The following is a description of a gene set: Mouse Gene Set: GOBP_REGULATION_OF_CELLULAR_COMPONENT_BIOGENESIS species: Mus musculus Any process that modulates the frequency, rate or extent of cellular component biogenesis, a process that results in the biosynthesis of constituent macromolecules, assembly, and arrangement of constituent parts of a cellular component., and this is the list of marker genes: Mtm1, Fhod1, Rpl13a, Enpp7, Pdlim4, Cln3 (NCBI Gene Id 12752), Tenm1, Map2, Spice1, Prkcq, Nrg2, Plcg2, Neurl1a, Cdc42ep1, Nol3, Wrap73, Cdh5, Akirin1, Kirrel1, Piezo1, Dync2li1, Ajuba, Gsn, Coro1c, Ptpn1, Mavs, Dlc1, Ubap2l (ubiquitin-associated protein 2-like), Arhgap6, Flna, Psd, Wnt10b, Nrxn1, Asic1, Nphp1, Arhgap33, Epha2, Rock2 (NCBI Gene Id 77848), Poc1b (POC1 centriolar protein B), Nek7, Sar1b, Dhx33, Vps35, Clec2i, Abcb7, Arpc5l, Vldlr, Becn1, Ect2, Tbc1d14, Rnf5, Mapk9, Apoa1, Cdc34b, Met, Camsap3, Hgs, Sacs, Chek2, Igsf11, Lcat, Abca1, Nr1h2, Ssh2, Atg5, Cd24a, Npm1, Trabd2b, Cldn3, Lamp2, Prkn, Dynll1, Eef2k, Hspa2, Capg, Lpar1, Gba1, Ccl26, Rap1b, Clip1, Arhgap44, Ulk1, Kank2, Plekhg2, Abi3bp, Chmp7, Brcc3, Vps4a, Nup62, Hcfc1, Grid2, Ckap5, Chd4, Rhoc, Stxbp6, Stmn1, Gpm6a, Usp17le, Cep295, Nectin1, Cdk2, Frmd7, Hsp90aa1, Srcin1 (NCBI Gene Id 56013), Ica1, Wipi1, Rims1, Slf2, Arpc3, Trim32, Vasp, Plce1, Hdac6, Rgcc, Palm, Ublcp1, Map4k4, Negr1, Ptger4, Tie1, Ptk2b, Espn (NCBI Gene Id 56226), Clstn1, Was, Smad4, Sorbs3, Tesk1, Nckap1l, Apod, Ulk4, Patl2, Ube3b, Trhr, Hrk, Mtpn, Tlr4, Pfn5, Ccn1, Osbpl2, Vil1, Dock1, Sec22b, Il1rapl1, Mapre3, Slain2, Stmp1, Ptpn22, Tfip11, Slit1, Lrrc24 (NCBI Gene Id 378937), Tbc1d30, Mmp14, Stmn2, Sipa1l1, Peak1, Plk2, Wnt4, Rnf186, Actr2 (actin related protein 2), Gpr65, Map1b, Dynlt2b, Cep97, Crb3, Prkaca, Scin, Bcl2l11, G3bp2, Cep135, Tgfbr1, Cyfip2, Sptbn1, Adgrl4, Arf4, Arhgef15, Iqsec1, Oprd1 (opioid receptor, delta 1), Ehmt2 (NCBI Gene Id 52041), Zdhhc8, Ikbke, Usp9x, Tchp, Vcp, Adgrb1, Chmp4c, Intu, Dnm2, Pdzd11, Fuz, Fas, Pecam1, Dnajc6, Abitram, Rps3, Sh3glb1, Mecp2, Hnf4a (NCBI Gene Id 15378), Lcmt1, Bag5 (NCBI Gene Id 74791), Usp10, Rac1, Carmil3, Prkch, Slit2 (NCBI Gene Id 338531), Mlst8, Mndal, Pan3, Gpsm2, Efnb3, Tbx5, F2rl1, Ep300, Slitrk3, Tmsb15l, Rhoa, Syngr3, Prkce, Dock4, Pum2, Eps8l3, Clstn2, Wnt7a, Il1rapl2, Sh3pxd2b, Marchf7, Kif14, Stxbp5, Fchsd1, Cobl, Rhpn1, Ticam1 (NCBI Gene Id 224899), Btk, Lmod3, Grin1, Arhgap40, Tubb4a, Unc13b, Ccsap, Zdhhc12, Trpm2, Dync1h1, Serpinf2, Icam1, Cdc42, Crocc (NCBI Gene Id 230872), Lefty1, Lrfn5, Rasip1, Cep76, Fer, Rab5a, Rack1, Hsf1, Capza3, Prrt2, Ntrk2, Sdccag8 (serologically defined colon cancer antigen 8), Nedd4l, Ifi213, Trim11 (tripartite motif-containing 11), Fam98a, Hmgb1 (NCBI Gene Id 15289), Lzts3, Podxl, Prkaa2, Lats2 (large tumor suppressor 2), Cux2, Shank3, Bax, Slx4, Snap25, Rab3gap1, Mark1, Snai2 (snail family zinc finger 2), L1cam, Selp, Isg15, Aida, Pip4k2b, Rhpn2, Birc2, Igtp, Ifi209 (NCBI Gene Id 98348), Fnip1, Rock1 (NCBI Gene Id 68785), Rab3a, Mdga2, Nf2, Sdcbp, Riok3 (RIO kinase 3), Isl1, Flii, Adgrl1, Arpc5, Ppp1r9b, Notch1, Adamts16, Mdm1, Bik, Amigo3, Esam, Napb, Lats1, Ripor2, Ormdl3 (NCBI Gene Id 66612), Ppfia1, Rbm10, Capn1, Vps4b, Svil, Twf1, Kank1, Snap91, Ppp1r35, Cldn1, Lrp4, Prkaa1, Ifi214, Arhgef5, Yap1, Htr4, Snx9, Slitrk5, Capza2, Epb41l5, Sema4a, Sema4c, Eln, Tac1, Ppm1f, Tnf, Trim47, Ormdl2 (NCBI Gene Id 66844), Def8, Tpm1, Tapt1, Mkks, Hspa1b, Sass6, Ddx3x, Hopx, Cript, Pex5, Prkcz, Terf1, Rbm14, Nrp1, Gda, Aqp1, Phldb1, Ephb2, Cgnl1, Lrrtm2, Arhgap28, D1Pas1 (NCBI Gene Id 98517), Creb1, Pfn3, Wars1 (NCBI Gene Id 640248), Akain1, Fbxl2, Cav3, Wdpcp (NCBI Gene Id 216560), Agrn, Slc12a5, Cbln2, Prune1, Evl, Tfrc, Ifi206, Crmp1, Sar1a, Cyria, Srgap3, Nlgn1, Snai1, Kat2b, Plek, Mtss1, Add1, Pikfyve, Nphs1, Clec7a, Abl1, Nck1 (non-catalytic region of tyrosine kinase adaptor protein 1), Chmp2b, Trappc12, Farp1, Srgap2, Stub1, Tppp3, Syk, Eif4g1, Noto, Baiap2l1 (NCBI Gene Id 66898), Oxt, Lima1, Ifnb1, St8sia2, Atg3, Pycard, Ncam1, Synpo, Chga, Sorl1, Fez1, Clu, Ttbk1, Rap2a, Ift140, Lingo4, Dbn1, Rab17, Dkk1 (NCBI Gene Id 13380), Ghrl, Fkbp4, Cck, Lrfn3, Ccl21d, Lzts1, Bid, Bdnf, Ccl11, Lmo4, Limk2, Cdc34, Ubqln2, Rac2 (NCBI Gene Id 19354), Adgrb3, Syndig1, Smad3, Dusp22, Slitrk6, Rac3, Dnajb1, Dlg1, Casp4, Lcp1, Mapk15, Srf, Col16a1, Trim31, Mdga1, Dapk3, Robo1, Msn (NCBI Gene Id 97596), Lrfn4, Rap1a, Ntng2, Cryab, Htt, Dact1, Mad2l2 (NCBI Gene Id 71890), Csf3, Tmem67, Vcl, Cep295nl, Hrg, Ptpn13, Clasp2, Cnot6, Plxnb3, Hck (hemopoietic cell kinase), Tal1, Eif4ebp1, Ptprj, Cdkl5, Mpp7, Sncaip, Inpp5j, Nlgn3, Arpc2, Lrrtm3, Myo3a, Jmjd6, Cttn, Arhgef10, Atat1 (alpha tubulin acetyltransferase 1), Pxn, Thy1, Mapt, Wnt11, Ifi207, Ttc8, Ikbkb, Ldb2, Ldb1, Rnf4, Gpbar1, Mstn, Wnt3a, Styxl1, Numbl, Prkca, Chmp2a, Sigmar1, Preb, Ndel1, Cdc42ep5, Ccl21b, Sirt3, Hspa8, Pak1, Nbdy, Csnk1a1, Ntn1, Atr, Tbc1d12, Plekhm1, Bin3, Nop53, Sh3yl1, Caskin1, Stam, Myo10, Arl2, Nme7, Tmod2, Daam2, Lhfpl4, Myadm, Skap1, Fmr1, Cx3cl1, Lrrc4b, Lrrn1, Fam107a, Dusp3, Cxcl13, Iqsec2, Rab11a, Wasl, Mtor, Plk1, Lrsam1, Nlgn2, Gak, Ahr, D7Ertd443e, Kcnk13, Adgrl2, Chmp1b2, Arhgef18, Stx18, Swap70, Dnaja4, Bbs10, Clrn1, Coro1a, Mettl18, Tgfb1, Ankra2, Adgrb2, Ube2m, Pde4dip, Slitrk1, Abhd17a, Hdac4, Chrnb2, Stx1a, Drg1, Zfp827, Xrcc5, Trp53, Abi3, Mefv, Ppp2r5b, Pfn2, Fermt1, Gja1, Pcsk5, Cldn19, Cdc42ep2, Irgm2, Map3k1 (NCBI Gene Id 26401), Gna13, Icam5, Cfl1, Flrt3, Senp6, Wnt1, Nckap1, Caprin1, Fermt2 (fermitin family member 2), Efnb1, Trem2, Dlg4, Gap43, Cdkn2a, Pqbp1, Klf5, Rtn4, Arhgef2, Hcls1, Cep192, Irx3, Zmynd10, Saxo1, Fhod3, Slx1b, S1pr2, Lmod1, Rab3gap2, Zmynd8, Nox1, Dnajb2, Pip4k2c, Rcc2, Cbln1, Cdh17, Lrrk2, Myo3b, Sphk1, Gdi2, Dut, Efna5, Cyfip1, Foxc2, Pik3r2, Lrrn3, Odad3, Abca2, Syne2 (NCBI Gene Id 630548), Stil, Wdr45, Nlrc3, Sirt2, Nae1, Napa, Ormdl1, Samd8, Rab11fip3, Wasf2, Slc39a12 (solute carrier family 39 (zinc transporter), member 12), Afdn, Cnot2, G3bp1, Sptan1, Mmp3, Mmp1b, Lgals3, Auts2, Rhod, Eps8, Id1, Ppm1e, Carmil2, Cdk5rap2 (CDK5 regulatory subunit associated protein 2), Csf2, Psrc1, Pdcd6ip, Rcc1, Pkp2 (NCBI Gene Id 71741), Carmil1, Traf2, Rictor, Cldn5, Vill, Ptpra, Sec16a, Tnfsf18, Tpr, Slk, Fez2, Rab7, Kdr, Fscn1, Chmp1a, Fgfr1, Pan2, Tppp, Pten, Cyld, Ambra1, Ift20, Fes, Ntrk1, Ercc1, Prickle1, Mien1, Kctd17, Sost, Capza1, Six4, Add2, Ankrd27, Bbs4, Ghsr, Ccdc15, Cdc42ep3, Gnl3l, Ntrk3, Usp16, Lrtm1, Nptxr, Baiap2, Ccl21a, Mapre1, Tjp1, Ikzf1, Ppp1r9a, Washc1, App, Chmp3, Wnt5a, Spta1, Ptpn11, Pak3, F11r, Ube2v2, Mcidas, Dbnl, Ccn2, Hap1, Snca, Lrtm2, Elavl2, Eps8l2, Lrrtm1, Epn1, Dag1, Sox9, Bbc3, Atp8b1, Epha7, Sema4d, Tenm2, Atmin, Prex1, Baiap2l2, Ifi208, Mapk8, Nck2 (non-catalytic region of tyrosine kinase adaptor protein 2), Flrt1, Tpbg, Dcdc2a, Evi5l, Prkd1, Src, Gpc4, Ctnnbip1, Tirap, Ralb, Slitrk2, Kiss1r, Sumo1, Myd88, Snx30, Rhoq, Akt1, Cep120, Pparg, Rab1b, Atp13a2, Has3, Terf2, Park7, Hspa1a, Dsg3, Ptk2, Dnajb6, Brk1, Apc, Eml3 (echinoderm microtubule associated protein like 3), Cntrob, Usp50, Cnot1, Ctnnb1, Ptprd, Atp7a, Numa1, Sdc1, Crtac1, Tbc1d7, Ephb3, Epha1, Shank1, Rala, Snf8, Cdk10, Rp1 (retinitis pigmentosa 1 (human)), Fam110c, Bag4, Lin7a (lin-7 homolog A, crumbs cell polarity complex component), Dock10, Hras, Alox15, Adgre5, Cc2d1a, Cldn7 (NCBI Gene Id 53624), Lin7b, Insm1, Ccl21e, Psmc6, Dab2ip, Gm14137, Fzd1, Nphp4, Hnrnpu, Bin1, Lims1, Crbn, Kif24, Rps6, Cand1, Entr1, Stxbp1, Srpx2, Mtmr3, Xaf1 (XIAP associated factor 1), Dpysl3, Stau2, Arhgef10l (Rho guanine nucleotide exchange factor 10-like), Colq (collagen like tail subunit of asymmetric acetylcholinesterase), Hes1, Tsc1, Plk4, Ace2, Git1, Mak, Dmtn, Thbs2, C9orf72, Moap1, Pak2, Dnajb8, Akap9, Rest, Dnm3 (NCBI Gene Id 98663), Cntnap2, Xlr3b, Chmp5, Camsap2, Arfgef1, Trim9, Sdc4, Kif21a, Med25, Pip4k2a, Myoc, Prickle2, Irgm1, Atg2a, Il17a, Thra, Mfn2, Inpp5k, Six1 (NCBI Gene Id 20471), Aplnr, Coro2b, Apoe, Ssh3, Asic2, Fmn1, Mtln, Phldb2, Enpp2, Pfn1, Limk1, Dock11, Trim37, Nupr1, Ppp2ca, Syp, Wdr44, Tlr2, Mir129-2, Fblim1, Tmsb15b2, Grb2, Tmeff2, Rapgef2, Rabep2, Cav1, Ccl21f, Rdx, Cd36, Tsg101, Phf23, Nedd8, Lrp1, Ifi203, Synpo2l, Tmc8, Il1rap, Mycbp2, Tacstd2, Gpm6b, Stx1b, Rapgef3, Raf1, Ptprs, Itgb1bp1, Sphk2, Macf1, Kit, Snx7, Myo5b, P2rx7, Spidr, Ogt, Anln, Has2, Tmsb4x, Jam3, Abi2, Tlr6, Rapgef1, Odf2l, Unc13a, Pik3r1, Epha3, Vegfa (vascular endothelial growth factor A), Kif9, Synpo2, Arhgap18, Capzb, Kank3, Zdhhc1, Ccp110, Farp2, Rhog, Bhlhb9, Smcr8, Psmc5, Ankrd53, Prkcd, Chmp4b, Poldip2, Hspa5, Fnip2, Trim65, Atm, Pdlim5, Gbp2, Traf3ip1, Cptp, Tmod3, Add3, Slitrk4, Pla2g6, Nrxn2, Myo1c, Smpd3, Dnajc15, Hax1, Eif2ak2, Il1b, Dctn1, Gsk3b, S1pr1, Mphosph9, Adnp, Camsap1, Ppp1r16b, Ifi203-ps, Dlg5, Vdac2, Syt11, Tgfb3, Mark4, Emilin1, Lmod2, Ccl19 (C-C motif chemokine ligand 19), Snx18, Spag5, Atg7, Nckipsd, Cotl1, Gm12250, Ace, Caly, Septin9, Lin7c, Arf6, Ssh1, Paqr4, Elapor1, Bmp7, Dcx, Hjurp, Avil, Cdkl1, Elmo1, Ncln, Svip, Clasp1, Ccr7, Vstm5, Odf2, Amigo2, Septin8, Map3k7, Eml2, Oxtr, P2ry12, Ift88, Nudt16, Arhgap24, Cenpj, Acvrl1, Kank4, Chmp6, Fnbp1l, Prl2c2, Dzip1, Malsu1, Fchsd2, Dclk1, Syne1, Cracd (NCBI Gene Id 75147), Pink1, Sgk1, Amigo1, Snx4, Eps8l1, Hip1r, Plek2, Clip3, Tppp2, Flot1, Tek, Tbcd, Lrrtm4, Arap1, Dyrk1a, Twf2, Hif1a, Slf1, Vps11, Abca3, Bmf, Myh9, Rab3ip, Mmp1a, Hyal1, Tmem39a, Cnot6l, Rtn4r, Tmod1, Clstn3, Nox4, Tmod4, Arhgap35, Ice1, Ttbk2, Arhgef7 (Rho guanine nucleotide exchange factor), Trim30a, Asap3, Limch1, Rtel1 (NCBI Gene Id 99386), Faf1, Cdkn1b, Luzp1, Ccdc88a, Ezr, Pld1, Il5, Braf, Rasa1, Tgfbr3, Alms1, Lrfn1, Togaram1, Grem1, Iqgap1, Agt, Fzd5, Nav3, Mef2c, Tacr1, Setd5, Bak1, Capza1b, Musk, Plppr5 (phospholipid phosphatase related 5), Ifng, Cd47, Ccl24, Rps6-ps4, Mns1, H3f3b, Zfp750, Rap1gap, Nrg1, Gbp5, Gdf2, Cpeb3, Lingo2, Chmp1b, Flrt2, Numb, Actr3, Stap1, Adgrl3, Cdc42ep4, Actg1, Scfd1, Nectin3, Sptbn2, Brsk1, Ift46, S100a10 (NCBI Gene Id 99776), Gba2, Antxr1, Arhgef9, Sptb, Slain1, Ephb1, Cyrib, Brcc3dc, Zdhhc5, Kat2a